The following is a description of a gene set: The process in which immune receptor genes are diversified through somatic mutation. studied in species Mus musculus Mouse Gene Set: GOBP_SOMATIC_DIVERSIFICATION_OF_IMMUNE_RECEPTORS_VIA_SOMATIC_MUTATION, and this is the list of marker genes: Msh3, Samhd1, Exo1, Msh2, Hmces, Ighd (immunoglobulin heavy constant delta), Polm, Adar, Pms2, Ung, Msh6, Mlh1, Polb, Nuggc, Aicda, Polq, Mcm3ap